Given this list of marker genes GBP1, TRIM22, ARID3A, EPRS1, PMAIP1, EIF3A, OAS2, FUBP1, IRF1, CYCS, B2M, IFI6, EIF2B1, IRF9, IL6, PLOD2, STAT1, NMI, IFI44, PLSCR1, AP3M2, IFI30, IFIT2, IFI16, IRF2, PLAUR, EPS15, CALD1, BST2, FOSL1, SSBP1, NAP1L1, IFITM1, TRAPPC10, TEAD1, BAG1, SP110, RBBP4, GMFB, RBMX, IFI35, ELF1, DNAJC2, C1S, SKP1, MX2, ZFP36L2, OAS1, RHOC, CTR9, CSRP3, BTG1, PSMB8, PML, XRCC6, TAP1, IFIT5, TRIM26, HADHB, LIPA, POLR2B, ISG15, SMAD4, OASL, EIF2AK2, IFIT1, ETS2, ADAM9, IFIT3, CASP8, SRP9, DDX21, MX1, HLA-C, PPP3CA, SEM1, TRIM14, MAP1B, PARP1, HLA-A, PPP5C, SRSF2, ITGA2, ATP6V0B, DDX1, PSMB10, HLA-E, PSMB9, MAP3K10, CD164, HIF1A (hypoxia inducible factor 1 subunit alpha), BCLAF1, PTPN11, HADH, PARP4, DDX17, ELK4, PDXK, CEBPD, TRIM21, ADAR, PSME1, IQGAP1, here is a description of the gene set: Human Gene Set: DER_IFN_BETA_RESPONSE_UP Genes up-regulated in HT1080 (fibrosarcoma) cells by treatment with interferon beta for 6 h. species: Homo sapiens The pleiotropic activities of interferons (IFNs) are mediated primarily through the transcriptional regulation of many downstream effector genes. The mRNA profiles from IFN-alpha, -beta, or -gamma treatments of the human fibrosarcoma cell line, HT1080, were determined by using oligonucleotide arrays with probe sets corresponding to more than 6,800 human genes. Among these were transcripts for known IFN-stimulated genes (ISGs), the expression of which were consistent with previous studies in which the particular ISG was characterized as responsive to either Type I (alpha, beta) or Type II (gamma) IFNs, or both. Importantly, many novel IFN-stimulated genes were identified that were diverse in their known biological functions. For instance, several novel ISGs were identified that are implicated in apoptosis (including RAP46/Bag-1, phospholipid scramblase, and hypoxia inducible factor-1alpha). Furthermore, several IFN-repressed genes also were identified. These results demonstrate the usefulness of oligonucleotide arrays in monitoring mammalian gene expression on a broad and unprecedented scale. In particular, these findings provide insights into the basic mechanisms of IFN actions and ultimately may contribute to better therapeutic uses for IFNs. from publication Der SD, Zhou A, Williams BR, Silverman RH (PMID 9861020)